The following is a description of a gene set: Genes down-regulated in SEND cells (skin endothelium) at hypoxia with ELK3 knockdown by RNAi. studied in species Mus musculus Mouse Gene Set: GROSS_HYPOXIA_VIA_ELK3_DN The ternary complex factor Net/Elk3 is downregulated in hypoxia and participates in the induction by hypoxia of several genes, including c-fos, vascular endothelial growth factor and egr-1. However, the global role of Net in hypoxia remains to be elucidated. We have identified, in a large-scale analysis of RNA expression using microarrays, more than genes that are regulated by Net in hypoxia. In order to gain insights into the role of Net in hypoxia, we have analysed in parallel the genes regulated by HIF-1alpha, the classical factor involved in the response to hypoxia. We identified about genes that are regulated by HIF-1alpha in hypoxia. Surprisingly, when we compare the genes induced by hypoxia that require either Net or HIF-1alpha, the majority are the same (75%), suggesting that the functions of both factors are closely linked. Interestingly, in hypoxia, Net regulates the expression of several genes known to control HIF-1alpha stability, including PHD2, PHD3 and Siah2, suggesting that Net regulates the stability of HIF-1alpha. We found that inhibition of Net by RNAi leads to decreased HIF-1alpha expression at the protein level in hypoxia. These results indicate that Net participates in the transcriptional response to hypoxia by regulation of HIF-1alpha protein stability. from publication Gross C, Dubois-Pot H, Wasylyk B (PMID 17704799), and this is the list of marker genes: Higd1a, Noct, Fbxo42 (F-box protein 42), Tnc, Csrnp1, Ptger4, Mmp8, Klf6, Pdlim4, Hspa5, Atf1, Ankrd1, Usp47, Zfp330, Lamp2, Ifi204, Ascc2, Jag1, Riok1, Cxcl1, Adipor2, Zfp398, Jmjd1c, Anpep, Cxcl10, Slc20a1, Vwa1, Aff1, Vegfa, Sat1, Tiam2, Ppp1r15a, Hilpda, Zbtb20, Tshz1, Depp1, Fgd6, Il6, Spry2, Cd44, Map3k1, Slc7a11, Ehf, Aldh1l2, Cavin3, Slc2a1, Fst, Acap2, Vldlr, Eno1, Dusp2, Txnl1, Pfkfb3, Samsn1, Srgn, Cdc42ep3, Csf3, Ifi202b, Akap12, Slc39a14, Hoxb9, Nfkbia, Ccn1, Itga6, Plek, Rnd1, Dmp1, Atf4, Bhlhe40, Ifrd1, Cth, Dzip3, Rad23b, Gadd45a, Hbegf, Cars1, Gzf1, Ero1a, Tgif1 (NCBI Gene Id 21815), Dusp4, Prdx5, Oas2, Snora28, Skil, Eps15, Adm, Il13ra1, Dhrs9, Tnfrsf23, Atxn2l, Ccl2, Prdm2, Angptl6, Plk2, Upp1, Klf4, Zfp36, Ramp3, Trps1, Fos, C3, Myh9, Rcan1, Nedd4l, Rad54b, Ndrg1, Rps6ka5, Gspt2, Nfil3, Ccn2 (NCBI Gene Id 215862), Ptgs2, Gfus, Pim3, Fgb, Smox, Cacna1h, Nedd9, Acsl4, Tcim, Tm4sf1, Kctd11, Asns, Vangl2, Lilrb4b, S100a8, Chic2, Rars1, Rbpj, Xbp1, Cebpb, Myc, Hax1, Ets1, Rabgef1, Ptbp3, Slpi, Cxcl2, Errfi1, Acbd3, Gbe1, Prkg2, Cxcl5 (C-X-C motif chemokine ligand 5), Mthfd2, Egr1, Apba3, Thbd, Cd93, Traf6 (NCBI Gene Id 99098), Scgb1b27, Edn1, Pnrc1, Igtp, Kif5a, Lhx9, Pdlim5, Gja1, Eprs1, Siah2, Scaf11, Bcl10